The following is a description of a gene set: studied in species Homo sapiens Proline and hydroxyproline pathways Human Gene Set: WP_PROLINE_AND_HYDROXYPROLINE_PATHWAYS, and this is the list of marker genes: OAT, PYCR1, PEPD, PRODH, ALDH4A1